The following is a description of a gene set: species: Homo sapiens The chemical reactions and pathways involving putrescine, 1,4-diaminobutane; putrescine can be formed by decarboxylation of ornithine and is the metabolic precursor of spermidine and spermine. Human Gene Set: GOBP_PUTRESCINE_METABOLIC_PROCESS, and this is the list of marker genes: PAOX, AOC1, ODC1, AZIN2, SAT1, SAT2, AGMAT, AZIN1